The following is a description of a gene set: Cell-extracellular matrix interactions species: Homo sapiens Human Gene Set: REACTOME_CELL_EXTRACELLULAR_MATRIX_INTERACTIONS, and this is the list of marker genes: ILK (integrin linked kinase), RSU1, FERMT2, ARHGEF6, ACTB, LIMS1, LIMS2, TESK1 (testis associated actin remodelling kinase 1), VASP, ACTG1, PXN, ACTN1, ITGB1, FLNC, PARVB, FLNA (NCBI Gene Id 8272), FBLIM1, PARVA